Given this list of marker genes Kcnj8, Kcna5, Kcne4, Kcnh2, Kcnd3, Kcne2, Kcne5 (potassium voltage-gated channel subfamily E regulatory subunit 5), Kcnj5, Kcne3 (potassium voltage-gated channel, Isk-related subfamily, gene 3), Scn2b, Kcnq1, Kcne1, Kcnj2, here is a description of the gene set: Mouse Gene Set: GOMF_VOLTAGE_GATED_POTASSIUM_CHANNEL_ACTIVITY_INVOLVED_IN_CARDIAC_MUSCLE_CELL_ACTION_POTENTIAL_REPOLARIZATION Enables the transmembrane transfer of a potassium ion by a voltage-gated channel through the plasma membrane of a cardiac muscle cell contributing to the repolarization phase of an action potential. A voltage-gated channel is a channel whose open state is dependent on the voltage across the membrane in which it is embedded. studied in species Mus musculus